Given this list of marker genes HSPH1, AXIN1, LORICRIN, EVX1, HSPA1B, HEXA, EFNA1, RPS6KA1, RAB31, LTBR, LGALS3BP, HSD17B10, KIF22 (kinesin family member 22), SMAD3, GNAI2, PPID, HSPG2, HSPA1A, ASNS, TGFB1, here is a description of the gene set: The cyclin D1 signature: genes whose expression correlated with the levels of CCND1. Human Gene Set: LAMB_CCND1_TARGETS from publication Lamb J, Ramaswamy S, Ford HL, Contreras B, Martinez RV, Kittrell FS, Zahnow CA, Patterson N, Golub TR, Ewen ME (PMID 12914697) studied in species Homo sapiens Here we describe how patterns of gene expression in human tumors have been deconvoluted to reveal a mechanism of action for the cyclin D1 oncogene. Computational analysis of the expression patterns of thousands of genes across hundreds of tumor specimens suggested that a transcription factor, C/EBPbeta/Nf-Il6, participates in the consequences of cyclin D1 overexpression. Functional analyses confirmed the involvement of C/EBPbeta in the regulation of genes affected by cyclin D1 and established this protein as an indispensable effector of a potentially important facet of cyclin D1 biology. This work demonstrates that tumor gene expression databases can be used to study the function of a human oncogene in situ.